The following is a description of a gene set: studied in species Homo sapiens Any process that stops or decreases the rate or extent of glial cell proliferation. Human Gene Set: GOBP_NEGATIVE_REGULATION_OF_GLIAL_CELL_PROLIFERATION, and this is the list of marker genes: TSPO, ABCC8, SOX11, NF1, RB1 (NCBI Gene Id 92728), RNF10, ASCL2, DICER1, HES1, TP53, NOTCH1, SKI, NF2, SOX10 (SRY-box transcription factor 10), MIR146A, CERS2, IDH2